The following is a description of a gene set: This event has been computationally inferred from an event that has been demonstrated in another species.<p>The inference is based on the homology mapping from PANTHER. Briefly, reactions for which all involved PhysicalEntities (in input, output and catalyst) have a mapped orthologue/paralogue (for complexes at least 75% of components must have a mapping) are inferred to the other species. part of: Processing and activation of SUMO Reactome Pathway: SUMO is transferred from E1 to E2 (UBE2I, UBC9) species: Mus musculus electronically inferred by orthology from the curated human pathway, and this is the list of marker genes: Rwdd2b, Sumo1 (NCBI Gene Id 22218)